The following is a description of a gene set: species: Homo sapiens A ribonucleoprotein complex that contains small nuclear RNA U2, a heptameric ring of Sm proteins, as well as several proteins that are unique to the U2 snRNP, most of which remain associated with the U2 snRNA both while the U2 snRNP is free or assembled into a series of spliceosomal complexes. Human Gene Set: GOCC_U2_SNRNP, and this is the list of marker genes: RNU2-1, SF3B4, DDX46, RBMX2, SF3B3, SNRPD2, SF3B1, SF3A2, SF3B6, SNRPG, SNRPB2, SNRPD3, SNRPE, SNRPB, SNRPA1, PHF5A (NCBI Gene Id 84844), SNIP1, SF3B2, SF3A3, U2SURP, SNRPD1, SNRPN, SNRPF, HTATSF1, SF3B5, SF3A1, SNRPGP15, BUD13